The following is a description of a gene set: studied in species Homo sapiens The process that mediates signaling interactions between one cell and another cell by transfer of current between their adjacent cytoplasms via intercellular protein channels. Human Gene Set: GOBP_CELL_COMMUNICATION_BY_ELECTRICAL_COUPLING, and this is the list of marker genes: ASPH, PRKACA, GJC3, CAMK2D, GJA1, GJB2, CALM2, ATP1B2, RYR2, IRX3, KCNA1, TRDN, ANK3, HRC, ATP1B1, SLC8A1, ATP1A2, TBX5, PKP2, GJA5, GJD3, PDE4D, CALM1, ATP1A3, CALM3, GJC1, SRI, CAV1, DBN1, CACNA1C, CASQ2, GJC2, ATP1A1, GJB6